The following is a description of a gene set: species: Mus musculus A proteasome complex found in the cytosol of a cell. Mouse Gene Set: GOCC_CYTOSOLIC_PROTEASOME_COMPLEX, and this is the list of marker genes: Uchl5, Psmc4, Psmc6, Ubqln4, Ide, Psmd14, Psmc5